Given this list of marker genes Gpd2, Fabp12, Lpin2, Gk, Fabp4, Fabp7, Fabp5, Gpat2, Fabp3, Fabp6, Gykl1, Dgat1, Pnpla5, Lpin3, Fabp9, Gpam, Mogat1, Fabp1, Dgat2, Fabp2, Gk2, Mogat2, Agmo, here is a description of the gene set: studied in species Mus musculus Triglyceride metabolism Mouse Gene Set: REACTOME_TRIGLYCERIDE_METABOLISM